Given this list of marker genes Dhrs4, Kdsr, Cyp4a12a, Miox, Pgd, Cyp4f13, Dhrs11, Idh1, Hmgcr, Dhrs7l, Akr1d1, Hsd17b12, Hsd3b7, Idh3g, Rdh8, Hpgd, Idh2, Sdr42e1, Sdr16c5, Akr1c19, Cbr4, Hsd3b3, Rdh16, Ldha, Rdh12, Ldhc, Cbr1, Akr1c12, Rdh10, Adh7, Hao2, Mdh2, G6pdx, Hsd3b8, Hadha, Dhdh, Tdh, Dhrs3, Akr1c6, Ldhal6b, Dhrs7c, Rdh5, Lipf, Hsd3b1, Rdh9, Adhfe1, Akr1e1, Impdh1, Hsd11b1, Dhrs1, Hao1, Cbr3, Cbr2, Hsd17b10, Akr7a5, Hsd3b4 (NCBI Gene Id 15495), Cbr1b, Uevld, Hsd3b6, Hsd17b11, Dhrs7b, Aldh3a1 (NCBI Gene Id 11670), Hsd17b1, Idh3a, Dcxr, Ptgr1, Hsd3b9, Me2, Gpd1l, Hibadh, Cyp4f18, Bdh2, Akr1c18, Akr1c14, Hsd3b5, D2hgdh, Chdh, Hsd17b7, Idh3b, Impdh2-ps, Kcnab2, Me3, Ugdh, Akr1c13, Sdr9c7, Cryl1, Hsd17b2, L2hgdh, Rdh16f2, Akr1b7, Fasn, Gpd2, Kcnab1, Mdh1, Akr1c20, Rdh19, Bdh1, Hsd17b4, Adh6a, Dhrs7 (NCBI Gene Id 70651), Rdh11, Sdr42e2, Cyp4a12b, Ctbp1, Akr1cl, Hsd17b13, Impdh2, Hsd17b8, Cyp4a14, Adh6b, Spr, Hsd17b3, Adh4, Dhrs2, Adh1, Hadh, Sord, Ldhd, Srd5a2, Akr1a1, Hsd17b14, Me1, Rdh7, Ldhb, Phgdh, H6pd, Cyp4a30b (NCBI Gene Id 435802), Mdh1b, Hsd17b6, Aldh3a2, Sdr16c6, Grhpr, Kcnab3, Akr1b1, Ctbp2, Adh5, Akr1c21, Rdh14, Gulo, Akr1b8, Akr1b10, Gpd1, Prxl2b, Nsdhl, Gfus, G6pd2, Ehhadh, Rdh13, Hsd11b2, Hsd3b2, Rdh1, Dhrs9, Cyp4a29, here is a description of the gene set: Catalysis of an oxidation-reduction (redox) reaction in which a CH-OH group act as a hydrogen or electron donor and reduces a hydrogen or electron acceptor. Mouse Gene Set: GOMF_OXIDOREDUCTASE_ACTIVITY_ACTING_ON_CH_OH_GROUP_OF_DONORS species: Mus musculus